Given this list of marker genes Bcl7b, Ss18 (SS18, subunit of BAF chromatin remodeling complex), Smarcd1, Smarcc1, Smarcc2, Smarca4, Smarca2, Ss18l1, Bcl7a, Bicral, Smarcd2, here is a description of the gene set: This event has been computationally inferred from an event that has been demonstrated in another species.<p>The inference is based on the homology mapping from PANTHER. Briefly, reactions for which all involved PhysicalEntities (in input, output and catalyst) have a mapped orthologue/paralogue (for complexes at least 75% of components must have a mapping) are inferred to the other species. Reactome Pathway: Formation of the non-canonical BAF (ncBAF) complex electronically inferred by orthology from the curated human pathway studied in species Mus musculus part of: SWI/SNF chromatin remodelers